The following is a description of a gene set: from publication Feuerer M, Herrero L, Cipolletta D, Naaz A, Wong J, Nayer A, Lee J, Goldfine AB, Benoist C, Shoelson S, Mathis D (PMID 19633656) studied in species Homo sapiens Genes up-regulated in comparison of regulatory T cells versus conventional T cells. Comparisons of global gene-expression profiles revealed a greater distinction between CD4+ Treg cells and CD4+ conventional (Tconv) T cells residing in abdominal (epidydimal) fat versus in more standard locations such as the spleen, thymus and LN. Human Gene Set: GSE7852_TREG_VS_TCONV_UP, and this is the list of marker genes: MATN2, ITM2C, CERK, HNRNPLL, VPS54 (NCBI Gene Id 51542), BCL3, RXFP1, KIF13A, NKRF, VWA5A, ERMP1 (endoplasmic reticulum metallopeptidase 1), FCGR2B, XXYLT1, PON3, N4BP1, IRF6, ARL5A, RALBP1, TNIP1, COMT, RAB3GAP2, TMEM158, EIF5A, ITIH5, NCKAP5, DNAH7, MED7, CALHM2, UBASH3B, AK3, ACOT9, FAR1, SWAP70, C3orf70, INF2, YPEL2, GNAQ, MAGED2, HEMK1, NIBAN1, GSTO1, INPP5F, IKZF2, CYSLTR1, RELB, PDCD1LG2, CLDND1 (claudin domain containing 1), ST3GAL2, SDC4, CPD, IL2RA, LRRC58, RHOD, SNX3, TGFBR1 (transforming growth factor beta receptor 1), ZNF862 (zinc finger protein 862), NDFIP1, SPECC1, SLC22A2, H2AZ1, LYRM4, MGAT5, TM7SF3, MCUB, LMAN1, AHI1, PAQR3, SOCS5, ISG20, TFRC, ALAD, PRNP, ZC3H7B, CORO2A, TMEM123, B9D2, BIRC3, EBI3, PENK, PLEKHB2, ZBED5, GALM, POLK, SYNGR2, CYTH4, NEB, MATK, NFKB1, LCLAT1, NEU3, CHCHD10, ATP5IF1, MTMR3, PDZK1IP1, TSPAN31, HOOK2, IRF8, ARRDC4, BID, ALOX15B, EEF2K, IKZF4, LONRF1, ARL6, TRIM14, LAPTM4B, PLP2, FAH, ATOSB, SCAMP1, PCTP, MIB1, MYO1E, CYP20A1, ACTR3B, NRN1, CD81, OGFRL1, ENDOD1, TMEM40, TNFRSF18, KIAA1958 (KIAA1958), C3orf80 (chromosome 3 open reading frame 80), PLCL1, REEP3, GMDS, ITGAE, CD83, GZMB, ANKRD6, ZFP36L1, DENND5A, NCMAP, SH3BGRL2, PPM1L, PMEPA1, PIP5K1B, SHE (Src homology 2 domain containing E), ARID5B, TNFRSF4, SH3BGRL, DUSP4, CD99L2, CISH, PLAGL1 (PLAG1 like zinc finger 1), CD80, BLTP3A, TNFRSF1B, PPP1R3F (protein phosphatase 1 regulatory subunit 3F), ABCC1, PHLPP1, WLS, PLCB4, BMPR2, CCR6, WNT3, PHTF2, ARMCX4, TIAM1 (TIAM Rac1 associated GEF 1), ELK3, PTPRS, CTLA4, TANK, SOCS2, NLRP5, C1QTNF12, ALDOC, VMP1, ERGIC1, USP27X, REPS1, BCL2L15, IL1R2, GKAP1, PLAGL2, AHCYL2, ANXA4, SP6, PRKRA, MDFIC, TNFRSF9, MAPKAPK3, ANKEF1, TMBIM4, SACM1L, C9orf152, MAPKAPK2, MAP3K8, TSPAN13, NCF4, NUCB2, ITGB8, RGS1, KCNK6, TMPRSS3, YBX3, PDCD1, CAPG, TNFRSF25, ELP5